The following is a description of a gene set: Human Gene Set: HP_ABNORMAL_GLOMERULAR_MESANGIUM_MORPHOLOGY An abnormality of the mesangium, i.e., of the central part of the renal glomerulus between capillaries. Abnormal glomerular mesangium morphology studied in species Homo sapiens, and this is the list of marker genes: CD2AP, CFHR5, OSGEP, GAPVD1, TRPC6, LAMB2, EMP2, MAGI2, NUP160, ACTN4, PAX2, WT1, COQ6, ANLN, PLCE1, MYO1E, COPA, NUP107, YRDC, ADA, APOL1, INF2, NUP133, NPHS2, AVIL (NCBI Gene Id 80056), PTPRO, CRB2, WDR73, TP53RK, SPRY2, NPHS1, NOP10, NUP93, KIRREL1 (NCBI Gene Id 55243), CD81, NUP205, ARHGAP24, NUP37, FN1, DAAM2, COL4A3, APOE, TBC1D8B, SGPL1, NUP85, ARHGDIA, GON7, ANKFY1, COQ8B